Given this list of marker genes PRSS2, PAICS, CTRB1, CEP72, AXIN2, WDR62, KRT23, ATG9B, RAD51AP1, DHX30, ERCC4, TYMS, PLCD3, CITED1, TNNI1, RNF149 (NCBI Gene Id 284996), PSRC1, MTHFD1L (NCBI Gene Id 80244), IFFO2, NEB, MAD1L1, TTBK2, NT5C3B, FZD6, ZFHX3, SPACA7, NDC80, EMP2, TPD52L1, FBLN2, NINL, SNX24, RASSF4, CD44, RGS12, ACP1, GLMN, CELA3B, CARNMT1 (carnosine N-methyltransferase 1), PHF21B, RGCC, KLHL8 (NCBI Gene Id 57563), ZFP1 (NCBI Gene Id 162239), TRIM9, ZNG1C, STOML1, TRIT1, DYNC2I2, CAGE1, WASF3, AGR3, CCT4, MEG3 (NCBI Gene Id 55384), SOX17, ADAT1, DMP1, MYC, PET100, PLA2G2F, RPRD1A, MRI1, SLC1A4, TCHP, ADCY8, LPCAT4, RNASE1 (ribonuclease A family member 1, pancreatic), CCDC86, CLASP2, TUBB2B, SESN2, CELA2A, FADS3, EIF5B, TXNRD3, HMGA2, ANAPC4, AOPEP, DCLRE1B, SP5, HOXA9, LRMDA, TBC1D7 (TBC1 domain family member 7), MUTYH, ATG16L2, TRIB1, TRMT9B, SYTL1, ILDR1, METTL13, DNLZ, TGIF2, FAM20B, SLFN12, EPHB2, ZNF780A, CENPP, ZNF800, TC2N, SOX9, AQP4, CYBRD1, GULOP, POLR3D, CDCA7, METTL2A, MRPS14, SOX4, CCDC163, HAGHL, SMYD5, PIEZO1, CCND2, DCTD, HSPBAP1, DYRK3, BRD8, CDC37, SHISA2 (shisa family member 2), CLDN11, SHMT2, MBOAT1, ARMC9, PSAT1, PASK, SNW1, MYCL, SRCAP, THOC1, SNHG12, TIAM1, MAPK4, CDK5RAP2, NFS1, ASCL2, HS3ST1, MMP15, GGH, EPHB3 (NCBI Gene Id 2049), ABCE1, PRDX2, TENM4, C18orf54, POLE, ELP1, MT4, SOAT1, TMEM131L, PLA2G15, ANKRD11, RNF43, NR2E3, PMM1, TXNL1, HIRA, GSDMA, LECT2, MYL7, TNFRSF19, ZNF184, PNLIPRP1, HOPX, ZSCAN21, BCL11A, VNN1, RNF157, CD80, SLC7A5, TNFRSF12A, TBC1D9, HMGCS2, TTC27, ZNF124, AKAP13, EDN1, FKBP5, ATRIP, KLK1, MRPL47, PACRGL, TRMT1, MYO1B, CABCOCO1, MND1, HHAT, EMC8, PRSS41, FGFRL1, ROR2, FGF1, SORBS2, TFIP11, ZNF746, DCAF4, IGFBP4, AFG2B, DUSP4, DIS3L, ORC5 (origin recognition complex subunit 5), SIVA1, HUNK, POGK, SLC12A2, EPN3, DGKB, SGF29, AFAP1L1, CPA1, DTL (NCBI Gene Id 51514), YJU2, here is a description of the gene set: The APC gene encodes the adenomatous polyposis coli tumour suppressor protein, germline mutation of which characterizes familial adenomatous polyposis (FAP), an autosomal intestinal cancer syndrome. Inactivation of APC is also recognized as the key early event in the development of sporadic colorectal cancers, and its loss results in constitutive activity of the beta-catenin-Tcf4 transcription complex. The proto-oncogene c-MYC has been identified as a target of the Wnt pathway in colorectal cancer cells in vitro, in normal crypts in vivo and in intestinal epithelial cells acutely transformed on in vivo deletion of the APC gene; however, the significance of this is unclear. Therefore, to elucidate the role Myc has in the intestine after Apc loss, we have simultaneously deleted both Apc and Myc in the adult murine small intestine. Here we show that loss of Myc rescued the phenotypes of perturbed differentiation, migration, proliferation and apoptosis, which occur on deletion of Apc. Remarkably, this rescue occurred in the presence of high levels of nuclear beta-catenin. Array analysis revealed that Myc is required for the majority of Wnt target gene activation following Apc loss. These data establish Myc as the critical mediator of the early stages of neoplasia following Apc loss. Human Gene Set: SANSOM_APC_TARGETS studied in species Mus musculus Genes up-regulated after Cre-lox knockout of APC in the small intestine. from publication Sansom OJ, Meniel VS, Muncan V, Phesse TJ, Wilkins JA, Reed KR, Vass JK, Athineos D, Clevers H, Clarke AR (PMID 17377531)